Given this list of marker genes VPS28, CHMP7, CHMP3, CHMP4B, VPS37D, CHMP6, CHMP4BP1, BECN2, VPS37B, TSG101, UBAP1, VTA1, STAM, LEPROT, STAM2, VPS37A, VPS4B, CHMP2B, VPS36 (vacuolar protein sorting 36 homolog), TMEM50A, CHMP4A, CHMP2A, CHMP5, VPS4A, CHMP1A, MVB12B, HGS, PIK3R4, CHMP1B, CHMP4C, MVB12A, TMEM50B, PTPN23, BECN1, VPS37C, VPS25, SNF8, LEPROTL1, here is a description of the gene set: The directed movement of substances from late endosomes to the vacuole. In yeast, after transport to the prevacuolar compartment, endocytic content is delivered to the late endosome and on to the vacuole. This pathway is analogous to endosome to lysosome transport. Human Gene Set: GOBP_LATE_ENDOSOME_TO_VACUOLE_TRANSPORT studied in species Homo sapiens